Given this list of marker genes Anxa4, Kcnq1, Gp2, Clca1, Stx3, Rab5a, Sycn, Dmbt1, Tmed2, Cuzd1, Scamp1, Tmed10, Pnliprp2, Slc30a2, Vamp8, Zg16, Slc9a4, Stxbp2, Vamp2, Rab27b, here is a description of the gene set: The lipid bilayer surrounding a zymogen granule. Mouse Gene Set: GOCC_ZYMOGEN_GRANULE_MEMBRANE species: Mus musculus